The following is a description of a gene set: studied in species Homo sapiens Any process in which macromolecules aggregate, disaggregate, or are modified, resulting in the formation, disassembly, or alteration of a ribonucleoprotein complex. Human Gene Set: GOBP_PROTEIN_RNA_COMPLEX_ORGANIZATION, and this is the list of marker genes: PWP2, SCAF11, LUC7L3 (NCBI Gene Id 51747), EIF3F, U2AF2, CLNS1A, TSSC4, HTATSF1, RNVU1-15 (NCBI Gene Id 105373467), SART1, DDX20, LSM2, RPS27L, PRKDC, KIF5B, SRSF10, PRPF8, DICER1, PRP4K, TARBP2, RPS6, MCAT, ATM (NCBI Gene Id 8068), SF3A1, RNU5E-1, PRPF31, VCP, RPL38 (NCBI Gene Id 6169), RPSA2, AGO2, SF3B5, RNU1-4, NCBP1, HSP90AA1, RPL11, RBMX2, NUFIP1, HSP90AB1, SRPK1, WEE2-AS1, SF3B6, CELF4 (NCBI Gene Id 56853), MDN1, EIF3E, LUC7L, RPS19, DDX1, STRAP, AGO4, GEMIN2, DKC1, CELF6, DHX29, SART3, GEMIN7 (NCBI Gene Id 79760), EIF4H, BUD13, EIF2D, RNU5A-1, MTG2, TAF9, XRCC5, MRTO4 (NCBI Gene Id 94394), DDX39B, RPS14, MCTS1, XAB2, RNVU1-14, YTHDC1 (NCBI Gene Id 91746), RNVU1-4, EIF3G, TGS1, MIURF, GEMIN8 (gem nuclear organelle associated protein 8), PRMT5, KLC1 (NCBI Gene Id 3831), PIH1D1, CELF5, RNU5F-1, EIF3I, TFIP11, GEMIN6, NAF1, PRPF3, RBM5, SF1, COIL, AGO1 (NCBI Gene Id 26523), PRPF39, DHX9, SRPK2, LUC7L2, EIF6, SF3A2, USP4, SNRPF, PRMT7, DYRK3, RNVU1-6, GEMIN5 (gem nuclear organelle associated protein 5), ABT1, RNU6ATAC, CLP1, SETX, EIF2S3, RUVBL2, RRP7BP (ribosomal RNA processing 7 homolog B, pseudogene), SHQ1, EIF3C, TRIM21, GCFC2, RPF2, SNU13, GEMIN4, DDX46, RNVU1-1, SNRPD3, MTG1, MCTS2, PUF60, ZRSR2, WDR77, RNVU1-2A, RPSA, SNIP1, SRPK3, RSRP1 (arginine and serine rich protein 1), RNVU1-3, PRPF18, DDX23, ERAL1, EIF3A, RNU4ATAC (NCBI Gene Id 57788), SRSF9, DDX42, RPL5, PTGES3, SNRPG, EIF4B, RNU11, SMN1, RNVU1-8, SNRPB2, PIH1D2, EIF3H, EIF3J, AAR2, SF3B2, DNAJC17, RNU4-1, MRPS7, EIF3B, ATR, EIF3K, PRPF6, RPS27, PHF5A, RPL10L, SNRPB, EIF2S2, SNRPD1, ZNHIT6, RRS1, MRM2, LSM4, RNU5D-1, NOPCHAP1 (NOP protein chaperone 1), RPL24, METTL17, PTBP2, SMN2, RNVU1-7, EIF5, BRIX1, YJU2, SFSWAP, SNRNP200, FAU, BOP1, RNU6-9, CELF3, PRPF19, RNU6-7 (RNA, U6 small nuclear 7), RNU6-1, TAF12-DT, SNRPD2, DHX30, RUVBL1, EIF3M, KHDC4, SNRPE, SF3B4 (splicing factor 3b subunit 4), RPS28, EIF2S3B, RNVU1-19, SF3B1, SF3B3, DENR, NOP2, USP39, FAF2, RPL13A, TXNL4A, SNRPA1, SLU7, RPS5, NOL3, DDX28, RNU5B-1, RNVU1-17, EIF3L, SF3A3, CD2BP2, CRNKL1, PRKRA, ZNHIT3, ZFAND1, SRSF6, FASTKD2, SRSF12, EIF3D, SRSF5, PSIP1, ADAR, NOP53, RCC1L, CELF1, SNRPC, AGO3, RNU4-2, SRSF1, CELF2, RNU2-1, NVL, ISY1, RPS15, RRP7A, EIF3CL